The following is a description of a gene set: studied in species Mus musculus The portion of the extracellular matrix that lies within the perisynaptic space. Mouse Gene Set: GOCC_PERISYNAPTIC_EXTRACELLULAR_MATRIX, and this is the list of marker genes: Hapln1, Tnc, Bcan, Ptprz1, Hapln3, Hapln4, Ncan, Vcan, Hapln2, Acan, Tnr